Given this list of marker genes KBTBD2, LTN1, SEL1L, UBAC2, DDI2, FBXO48, HAMP (hepcidin antimicrobial peptide), CUL4A, PLK1, FBXL18, PANO1, TMEM129, TAF9, KLHL17, GID8, UBE2U, PPP2CB, FEM1B, UMOD, PSMA8, PSMD12, RHBDF1, DAB2, USP5, TMUB2, FBXO6, PRAMEF7, NUDT15, PSEN1, WFS1, UBE2J1, APPBP2, USP25, PSMD6, DNAJB9, MAP1A (microtubule associated protein 1A), AXIN2, SIAH1, PSMC6, TAF1, JKAMP, UBE2D3, DNAJB2, SOCS6, FBXO27, FBXL20, RNF187, FBXO11, FBXL5, YOD1, PRAMEF10, CUL1, PSMB11, FBXL19, ATF6, SVIP, DERL1 (NCBI Gene Id 79139), EPM2A, SUMO2, NUB1, UBE2G2, USP7, KEAP1, FBXL15, GPX1, TNFAIP1, ANAPC13, PSMB7 (NCBI Gene Id 5695), TLK2, RBCK1, UBXN10, PKD1, RHBDD1, FBXL7, RNF170, ANAPC4, LRRK2, IFT80, OPHN1, RNF175, ZYG11B, PRAME, KLHL23, UBE4A, KLHDC1, UBE2C, PMAIP1, DET1, AQP11, WNT10B, GLMN, ARRB2, USP9X, DCAF12, TBX21, RNF216, KLHL5 (NCBI Gene Id 54163), HSPA5, TRIM45, TMF1, ERCC8, DDRGK1 (NCBI Gene Id 65992), ALAD, UBB, RPL11, GID4, CUL3, KLHL2, KBTBD7, KLHL4 (kelch like family member 4), TTC36, FZR1, ARHGAP5-AS1, CUL4B, PINK1, PRAMEF27, KLHL35, RNF139, KLHL41, MARCHF6, CBFA2T3, UBQLN4, XPO1, NPLOC4, ANAPC16, UBXN2B, TOPORS, WDR26, F8A3, KLHDC3, ARIH2, TRIM9, SH3RF3, FBXW4, RMND5A, PSMC4, CTNNB1, TRIM38, GBA1, NEDD4L, IL33, UBE3A, CCIN, PRAMEF19, SEM1, CDC34 (cell division cycle 34, ubiqiutin conjugating enzyme), DVL1, UBQLN3, FBXL22, ZER1, HERPUD1, PSMB5, GCLC, CEBPA, CSNK1E (casein kinase 1 epsilon), UBXN4, AURKA, RNF10, RBX1, ARRB1, SPOPL, NFE2L1, PHF20L1, UBE2A (ubiquitin conjugating enzyme E2 A), KLHL38, CUL2, RFFL, FBXO38, UBXN6, SKP1, TRIM72, FAF1, CAMLG, GABARAP, KCTD5, MAEA, SIRT2, RNF186, FBXL16, ERLIN2 (NCBI Gene Id 140906), TRIM3, LRRC75A, NAGLU, STUB1, PSMD2, CSNK2B, CDC23, PSMD14, RMND5B, PSMD1, PML, TMUB1, DERL2 (derlin 2), PRAMEF18, PSMF1, PCBP2, RNF185, UCHL5, FBXO9, PRAMEF26, ZNF418, ANAPC10, ERLIN1, ASB11, UBR1 (ubiquitin protein ligase E3 component n-recognin 1), WAC, ARMC5, RNF122, RNFT2, HSP90AB1, TMEM67, UBE2G1, UFL1, FBXO17, DMAC2, PSMC5 (proteasome 26S subunit, ATPase 5), GSK3B, PLK3, CDC16, NFE2L2, PSMA1, PSMA2, RNF5, RNF4, PSMB3, FAF2, DDA1, UBE2K, TRIM71, SKP2, HSPA1B, RAD23A, KLHDC2, SDF2L1, PRKCG, ASB9, FBXW7, FHIT, TRIM25, TRIM28, ADRM1, KLHL7, PSME2, SH3RF2, NHLRC3, NCCRP1, KAT5, AKT1, CDC26, FBXO7, HSP90B1, FBXW11 (F-box and WD repeat domain containing 11), FBXL2, SMURF2, HECTD3, UBE2H (NCBI Gene Id 7328), RNF34, USP19, PRAMEF33, FBXW5, OSBPL7, RHBDD2, HECTD1, NEMF, CDC20B, CRBN, KIF14, PBK, SOCS2, APC, RCHY1, PSMD4, TRIB3 (NCBI Gene Id 57761), WWP1, WWTR1, PCNP, KCTD10, KLHL29, CALR3, F8A2, KLHL15, USP38, F8A1, UBE2D1, PSMB1, PRAMEF20, KLHL6, DCAF1, PSMD11, SEC61B, ZNRF1, ASB2, DCAF11, PSMD8, CDC27, NR1D1, DESI1, KLHL22, TREM2, PRKN, ASCC2, COP1, FOXRED2 (FAD dependent oxidoreductase domain containing 2), RNF121, CANX, KLHL3, KLHL42, WWP2, PSME3, TRIP4, DNAAF4, ECSCR, KLHL20, RNF180, HSPBP1, PSMB2, TRIP12, SYVN1, FBXO44, KLHL40, CLGN, TBL1XR1, KCTD17, ZNRF2, PSMC3, RFPL1, UBE2J2, CDC20, KLHL1, MIDN, DDIT3, IPP, ANAPC2, PRKACA, SIAH3, MAN1C1, STYX, SPSB4, SMARCC1, ASB1, PELI1, MAN1A1, SHH, DTL, NEURL3, RACK1, HFE, OGT, HUWE1, USP44, FBXL4, ANAPC1, TRIB1, FBXL6, SH3RF1, UBXN11, PSMB6, DTX4, USP13, KCTD13, PRAMEF14, TRIM2, PSMB4, AMFR, PRPF19, PSMD13, VHL, AUP1, DNAJC10, MDM2, PSMB8, HERC2, PJA2, AMN1, CSNK1A1, PSMA3, PARK7, FBXL17, TMEM259, RNF126, PEX12, PSMB9, PSMA4, PSMB10, RNF41, PSME1 (proteasome activator subunit 1), ANKZF1, ELOB, FEM1A, KLHL21 (NCBI Gene Id 9903), XBP1, PSME3IP1, GSK3A, DDB1, SENP1, TRIB2, BTRC, RHOBTB3, ANAPC15, FBXO4, RYBP (RING1 and YY1 binding protein), KLHL30, PRAMEF5, KCTD2, PRAMEF12, PSME4, UBXN7, RCN3, CHFR, PIAS1, FBXO39, ANAPC5, APOE, GABARAPL2, STT3B, ZSWIM8, UBQLN2, SIRT1, PRAMEF4, KLHL8, KLHL12, SGTA, BAG2, TOR1A, CUL5, PSMC1, EDEM3, CALR, DERL3, SIRT6, MTA1, PRAMEF13, HM13 (NCBI Gene Id 92622), UBXN1, CCNF, SPSB1, RNF145, ZFAND2A, KLHL24 (NCBI Gene Id 79965), UCHL1 (ubiquitin C-terminal hydrolase L1), BRINP1, FAM8A1 (NCBI Gene Id 51439), BRSK2, BFAR, ENC1, PEX10, DCAF13, PSMC2, ECRG4, ZFAND2B, FBXL3, UBE4B, PSMD3, UBE3D, ECPAS, FMR1, PRAMEF22, FBXO46, UBR3, BIRC2 (baculoviral IAP repeat containing 2), UFD1, PABIR1, GIPC1, PRAMEF11, CCDC47, KLHL18, COMMD1, FBXO31, BAG6, ARAF, SUMO1, CAV1, SOCS7, ANAPC7, PSMD7, TRAF4, DNAJB12, PITHD1, PABPN1L, CSNK2A2, SPSB2, BAG5, PRAMEF9, PRAMEF25, FBXL14, ANAPC11, ASCC3, N4BP1, CLOCK (NCBI Gene Id 9575), MARCHF7, USP26, MAPK9, PSMA6, GET4, PRAMEF15, UBE2B, GAN, SPSB3 (NCBI Gene Id 90864), SHARPIN, FOXF2, IVNS1ABP, ATXN3, UBR5, APC2, AXIN1, KCMF1, NHLRC1, ARMC8, KLHL10, EIF3H, CCAR2, KBTBD8, HSPA1A, TF, KLHL28, ITCH, PRAMEF17, ATE1, PRAMEF6, UBQLN1, KBTBD3, IFI27, EDEM1, PSMD10, CLU, TRIM13, MAN1A2, OS9, FBXL13, BMAL1, PRAMEF2, TRPC4AP, SMURF1, UBXN8, TMTC3, VCP, FBXO22, UBE2N, KLHL11, TBL1X, SPOP, SOCS5, PSMA5, UBE2S, NOP53, SMAD7, SIAH2, DAB2IP, BBS7, TRIM39, PPP2R5C, PSMA7, AMBRA1, FBXO2, MTM1, MAN1B1, RAD23B, CDK2, UBE2W, PRAMEF1, UBR4, TRIM26, UBR2, BCAP31, PAQR3, RNF103, LAMP3, NUPR1, KBTBD6, KBTBD12, FBXW8, TMX1, PLAA, ANKRD9, FBXO3, CSNK2A1, NKD2, AGAP3, NSFL1C, ZNF598, SEL1L2, AFG2B, RNFT1, DDI1, KLHDC10, ZNRF4, PRICKLE1, SH3BGRL, USP14, RNF7, PRAMEF8, CSNK1D, SELENOS, GNA12, KCNE2, ERLEC1, TRIM21, SOCS4 (suppressor of cytokine signaling 4), UBXN2A, FBXO45 (F-box protein 45), MIR128-1, AKIRIN2, UBR7, FEM1C, EDEM2, ATXN3L, here is a description of the gene set: species: Homo sapiens Human Gene Set: GOBP_PROTEASOMAL_PROTEIN_CATABOLIC_PROCESS The chemical reactions and pathways resulting in the breakdown of a protein or peptide by hydrolysis of its peptide bonds that is mediated by the proteasome.